Given this list of marker genes IGF2, MGP, PDK3, AGTR2, NCAM1, F2R, ENO2, SLC16A1, FGF7, HMGN2, SLC38A2, TOP1, SLC12A2 (NCBI Gene Id 6558), EMB, PGRMC1 (NCBI Gene Id 10857), PTX3, IMPACT, CTSB, LTBP2, THBS2, THY1, CCNB2, CDO1, SYNPO, NOCT, CASK, LAMA4, SLC6A8, THBS1, SRRT, ADAM19, MAGED1, SMOC2, LOXL1, IVNS1ABP, CRABP1, PHLDB2, CSF1, PDK4, PLA2R1, UTP14A, NOC4L, TMEM176B, DPEP1, PPID, TWIST1, BACH1, CEBPD, CAPN6, PCF11, PFN2, IGSF10, ANK3, OSMR, RAMP3, CCL2, ERRFI1, CEBPB, APBB1IP, ATP13A3, GREM2, CYP1B1, H2AX, EFNB2, TAF1D, LMO7, CASP4, FGFR2, PRXL2A, PHLDA1, HAS2, CHI3L1 (NCBI Gene Id 7836), HTATSF1, CXorf38, GTF2A2, IL1R1, MAN2A1, PLPP3, DLK1, LPAR1, ENAH, PSPC1, NPNT, PTEN, IL1RL1, LSP1, HMGA2, IL6, NGEF, XDH, RAB11A, CXCL6, LXN, PLSCR1, HNRNPU, LAMP2, EIF2AK4, AOX1, SRSF6, FAM3C, VCAM1, C3, MYL12B, NAP1L1, TNC, ANP32E, NAV2, RBM3, TMEM176A, PDPN, PYHIN1, EVL, UBE2D2, TPST1, SRSF3, IFI16, SEPHS2, VCAN, GPC4, NID1, HSP90B1, here is a description of the gene set: from publication Chiaradonna F, Sacco E, Manzoni R, Giorgio M, Vanoni M, Alberghina L (PMID 16607279) Human Gene Set: CHIARADONNA_NEOPLASTIC_TRANSFORMATION_CDC25_UP studied in species Mus musculus Mutational activation of ras genes is required for the onset and maintenance of different malignancies. Here we show, using a combination of molecular physiology, nutritional perturbations and transcriptional profiling, that full penetrance of phenotypes related to oncogenic Ras activation, including the shift of carbon metabolism towards fermentation and upregulation of key cell cycle regulators, is dependent upon glucose availability. These responses are induced by Ras activation, being specifically reverted by downregulation of the Ras pathway obtained through the expression of a dominant-negative Ras-specific guanine nucleotide exchange protein. Our data allow to link directly to ras activation the alteration in energy metabolism of cancer cells, their fragility towards glucose shortage and ensuing apoptotic death. Genes up-regulated in reverted NIH3T3 cells (fibroblasts transformed by activated KRAS which then reverted to normal cells upon stable over-expression of a dominant negative form of CDC25) vs normal fibroblasts.